The following is a description of a gene set: Any vesicle-mediated transport that occurs in a synapse. species: Homo sapiens Human Gene Set: GOBP_VESICLE_MEDIATED_TRANSPORT_IN_SYNAPSE, and this is the list of marker genes: NRG1, TOR1A, ATP6V1F, ATP2A2, FBXO45, SLC17A5, ATP8A1, PPP3CC (NCBI Gene Id 5533), ATP6AP2, CBLB, CPLX3, ABCA13, ATP6V0A1, NSG1, TPRG1L, ARHGDIA (NCBI Gene Id 396), ATP6V1G3, SUSD4, ARC, HPCA, SLC17A7, PLD1, RPH3AL, CLTB, SNAPIN, USP6, WNT7A, SYNJ2, DNM3, AP3M1, PTEN, VAMP4, SYNJ1, PIK3C3, SYT1, RIMS2, ACTG1, SLC18A1, AP3S2, SYT12, RPH3A, SACM1L, ATP6AP1, P2RX1, BTBD9, PRKN, CADPS, VAC14, RIMS4, PREPL, EPS15, SEPTIN5, RAP1BL, PRKCG (NCBI Gene Id 57013), PPP3R1, GAK, BSN, RAB8A, SYT11, TBC1D24, SLC2A4, SYT17, CACNB4, AP2A1, DOC2B, ATP6V0D1, RAB5A, SNAP25, VAMP2, UNC13C, CADPS2, SYNDIG1, PACSIN1, PCLO, CDH2, BTBD8, STON1 (stonin 1), ATP6V1B1, RAB7A, CSPG5, EFNB2, STX1B, GIT1, STX2, NLGN3, CALM1, NECAP1, SYT8, CASK, NUMB, RIMS3, PLAA, OPHN1, NLGN2, CTBP1 (C-terminal binding protein 1), AP1G1, NCDN, NPY, PCDH17, HIP1, GRIP2, AP3M2, BLTP1, RIMS1, PLS3, SYNGR3, OSBPL2 (oxysterol binding protein like 2), STON2, P2RY1, SV2C (synaptic vesicle glycoprotein 2C), CALM2, FCHO2, STX11, AP2B1, PFN2, GIT2, RABEP1, STXBP3, ITSN1, ATP6V1A, LPAR1, MYLK, SLC17A6, VPS18, STX3, SYT9, MX2, ATP6V1E1, DNM2, NLGN1, SNAP29, STX1A, PSEN1, SNPH, CANX, SYN2, MX1, PARK7, SNCG, ATP6V1D, SCRN1, MKLN1, DVL1, PPFIA3, ROCK1, RALA, AP2S1, BRSK2 (BR serine/threonine kinase 2), SYT13, P2RX7, ARF6 (ADP ribosylation factor 6), SLC17A8, SYT4, RAB27B, PIP5K1C, ATP6V1G2, SH3GL2, DRD4, LRRK2, BIN1, DNAJC6, STXBP1, PPP3CA, STX19, CPLX2, ATAD1, AP3D1, ATP6V0C, ITGB3, DOC2A, SGIP1, CPLX4, ARPC3, SNCA, SYT2, RNF220, SNAP47, ATP6V0A4, DTNBP1, EPS15L1, VPS35, CPLX1 (complexin 1), GPR151, SYP, PRKCB, SLC32A1, OTOF, STXBP2, ITSN2, ATP6V1C1, UNC13A, SYN1, RAPGEF4, SNX9, RAB3GAP1, STXBP5, CALY, BRAF, CAPN2, NAPB, FBXL20, CASP3, PPP3CB, AAK1, GRIK5, AP2A2, CACNA1B, CLCN3, RAB11A, SV2B, CLSTN1, EFR3A, DNAJC5 (DnaJ heat shock protein family (Hsp40) member C5), DNM1, SYT7, SNCB, RAC1, GSG1L, CDK5, AP3S1, CLTA, SLC18A2, NAPA, SCRIB, PRKAR1B, SNAP23 (synaptosome associated protein 23), NRXN1, AMPH, AP3B2, ERC2, AP2M1, RAB4A, USP46, CTNNB1, BRSK1, RAB3B, SLC4A8, MDM2, GRIPAP1, PRRT2, ATP6V1G1 (NCBI Gene Id 9550), PLD2, CALM3, PPFIA2, RAP1B, TAMALIN, RAB3A, SYN3, SYT5, FMR1, DGKQ, SV2A, ATP6V1B2, SYT10, WNT3A, UNC13B, RAP1A, BLOC1S6, ACTB, C9orf72